The following is a description of a gene set: Human Gene Set: MIR4475 species: Homo sapiens from publication Chen Y, Wang X (PMID 31504780) Genes predicted to be targets of miRBase v22 microRNA hsa-miR-4475 in miRDB v6.0 with MirTarget v4 prediction scores > 80 (high confidence targets)., and this is the list of marker genes: PLG, MARCKSL1, DMRTC1, CRELD2, FSTL4, SLC39A9, INPP4A, SMARCC2, IGFBPL1, ELOA, TRIM14, PDE7A, ZNF473, MED12L, PPM1B, SSR1, RBM39, PJA2, BCL11A, SOX4, ABCG2, UFM1, CYB5R2, MAP3K2, HAPLN4, MPC2, SMARCA5, PLGLB1, CEP44, NPAT (nuclear protein, coactivator of histone transcription), GEM, CRIPT (CXXC repeat containing interactor of PDZ3 domain), CLSTN2, MIB1, CCDC150, PCDHB4, PLGLB2, UGDH, SPSB3, SIPA1L2, USP8, U2SURP, DMRTC1B, TTF1, ZFHX3, RNF38, MEF2C, RPS6KA3, ZIC3, KCNB1, DGKH, ERC2, PIP4P1, ZNF24 (NCBI Gene Id 7744), UBE4B, RABL3, YTHDF2, FEZ1, GRHL2 (NCBI Gene Id 79977), CTBP2, ZFP28, RASGEF1B, PRDM16, ZNF559-ZNF177, ANOS1, CDC23, CD44, DST (dystonin)